The following is a description of a gene set: species: Homo sapiens The action of a molecule that contributes to the structural integrity of a synapse. Human Gene Set: GOMF_STRUCTURAL_CONSTITUENT_OF_SYNAPSE, and this is the list of marker genes: ACTN1, SPTBN2, ACTG1, ACTBL2, SHANK1, POTEI, POTEJ, ACTN2, NEFL, INA, ERC1, PPFIA2 (NCBI Gene Id 8499), ERC2, ACTB, POTEF, POTEKP, NEFH, RIMS1, RAPSN, RIMS2, DBNL, RIMS3, BSN, ACTL8, POTEE, PLS3, DLG1, PCLO, GIT1